The following is a description of a gene set: Reactome Pathway: Regulation of MITF-M-dependent genes involved in cell cycle and proliferation Depending on the overall level of activity, MITF may have a proliferative or antiproliferative role. In what has been termed a rheostat model of action, low-levels of MITF activity are associated with dedifferentiation, invasion, p27kip (CDKN1B)-dependent cell cycle arrest and low proliferative rates, while higher MITF activity drive proliferation by upregulation of cell-cycle and mitotic genes such as CDK2, CCNB1, CCND1, MET, PLK1, CENPA and NDC80. At even higher MITF levels, cell-cycle is arrested by virtue of expression of p21 (CDKN1A) and p16 (CDKN2A). This rheostat model of MITF activity and target gene expression can also be used to describe the role of MITF in the development of melanoma, with activation of different groups of target genes driving proliferation and invasion without activation of pigmentation genes. part of: MITF-M-dependent gene expression studied in species Homo sapiens, and this is the list of marker genes: HDAC1, TCF7L2, HINT1, MET, CDKN1A, CTNNB1, CDK2, TBX2, TCF7L1, SIN3A, CCND1, LEF1, CDC25B, TCF7, PLK1, CCNB1, MITF, CDKN2A